Given this list of marker genes JADE1 (NCBI Gene Id 79960), SLC7A5P2, SGK3, SLC44A1, AP3B1, KLHL18, OBSL1, HSD17B12, VIM, FAXDC2, PNISR, DNAJC16, NAA38, STXBP2, POLL, PLPP1, ATP6V1G1, CCT7, TLE2, USP10, OIP5, PKMYT1, AKIRIN2, P4HA1, GNG12, NUDT5, RSRC2, ILF2, IQCK, EIF2AK3, ANP32A, CABLES1, DPPA4, H2AZ1, BAMBI, SPRY1, GANC, SNUPN, GBF1, TMEM160, SFT2D3, CETN3, AURKA, DCX, ZNF684, SNRPN, ING4, ZNF398, RPP25, CHD2, UBC, ELP6, RPRD1A, TTC31, GSK3A, APH1A, PHGDH, FAM131B, TSPAN6, RPS18, ZNF112, FAM124A, SP2, CAND1, SLC36A4, TMEM59, CLIC1, MOV10, FZD8, RYR3, PKIB, SNRNP70, NSD3, SELENOP, PSMD9, DDX20, HNRNPA2B1, MEF2A, VPS35, ERCC1, SPART, PEA15, LEFTY1, NOC3L, JUN, OGA, METTL8, OTUD7B, MZT2A, ID2, COA8, VCAN, AHSA1, ABHD2, GOLIM4, FOXO3, SF3B5, WWC3, BRK1 (NCBI Gene Id 55845), PPP2R3A, ZSCAN32, TCERG1, PLEKHG3, EIF4ENIF1, PHF8, BZW2, ARMC6, NT5C2, PEX1, PTN, C12orf60, DHDDS, THAP1, EXTL2, CTSV, ING1, PEX2, KRR1, RIPK1, PNMA1, CASP9, RNF25, PRPF31, DIDO1, TCF7L1, UXS1, CALB1, HMG20A, CKS2, AK4, TOP2A, TMEM109, DDX17, TAF4B, ARID5B, ERH, SEPTIN6, GTPBP3, CHST4, TRIP10, MSH2, TBL1XR1, ICMT, HNRNPH2, TRIML2, PPP1R16B, C1orf54, SPIRE2, PGAP3, FBXO31, ARIH1 (ariadne RBR E3 ubiquitin protein ligase 1), DDX5 (DEAD-box helicase 5), GGA1, POLR3D, STRN, AVL9, SLC7A5P1, C20orf96, MTFR2, B3GALT4, VWA5A, ENTPD1, TMEM108, TARBP2, GNPTAB, JUP, AP2A1, MLH1, FZD2, COMMD3, SCGB3A2, RAD54B, DDX39A, ERBB2, FGF2, TNPO1, FANCA, CDK1, CBX5, TDRP, ENPP2, PRPF38A, DDX18, SORBS1 (NCBI Gene Id 80057), BUB3, TLE3 (TLE family member 3, transcriptional corepressor), TIA1, UFM1, PREPL, CDK14, SERP1, WBP11, BMP2, HEXIM2, ZIC2, EPS15L1, PSENEN, FUS, RNF121, PIM2, NSMCE3, PRPF19, TMEM259, GART, CHCHD5 (NCBI Gene Id 84269), LSM5, ISOC2, FARSA (phenylalanyl-tRNA synthetase subunit alpha), ASCC2, TBCC, DDA1, SIN3B, CAVIN3, KLF5 (NCBI Gene Id 688), MRPL27, CYP1B1, NVL, GLUD1, RAI1, SART3, PALS2, POU5F1, RAD23A, RAB38, H2AX, SLIRP, SARAF, CA4, BAG5, SGK1, PWP1, DCAF13, PIPOX, CLN3, LEPROTL1, DYM, NEDD4L, TRPC4AP, PPP2R1A, MSL3, PPP2R1B, RPL21, AJUBA, ECPAS, H2BC5, SUPT4H1, GATAD1, ZSCAN10, DCAF11, GNAI1, BCKDHA, CFAP298, RARB, HMBOX1, IDH3A (isocitrate dehydrogenase (NAD(+)) 3 catalytic subunit alpha), FBXW11, MAP1LC3B, ZNF516, MTM1, TCEAL8, CCDC93, TFPT, RPS26, SEC24A, ZNF281, RAB25, LAMA4, RANBP10, COX6A1, INF2, GXYLT1, SLX1B, CLMP, TMEM208, EIPR1, TBK1, DDX49, TTF2, DNAJC2, CIBAR1, ZFP36L1, PSMB5, ADO, MORF4L1, ZNF521, USP3, VPS52, GPC6, VRK2, KLF7, ANKRD1, PNP, GLA, IGDCC4 (immunoglobulin superfamily DCC subclass member 4), PARP8, RBBP4 (RB binding protein 4, chromatin remodeling factor), IGF2BP3, COL4A6, PAPSS2, TRIP4, PRPF39, MOB3B, TXNRD1, MAPK14, OXA1L, SON, CEBPZ, NODAL, PITX2, EPHA1, FEZ1 (NCBI Gene Id 9638), HSPA5, UBE2T, CDC123, SEC22C, GYPC, DVL2, GRK3, PPP1R2, RAB5B, S100A11, RSPRY1, RRS1, TOMM40L, GLIPR2, RPS27A, ARID1B, POLR1A, RESF1, AP1S2, GOLGA4, DCTN5, MCTS1, MKRN1, DNAJC9, DNAAF9, LRRC49, TPX2, COG7, FEM1A, UBE2S, SPARC, CDYL, BAG6, RBM4, FOXO1, FANCF, TMEM245, RPLP1, AKIRIN1, HNRNPUL1, MAN2C1, OAZ2 (NCBI Gene Id 4947), ORC1, FAM72B (family with sequence similarity 72 member B), CA2, NKTR, AASDH, VOPP1, PSMD14, ALKBH1, IGFBP2, HCFC1R1, CFAP68, TSC22D1, RNF2, CPT1A, SEC22B, SDC4, NPAS2, PKIG, TFB2M, BCL9L, SENP2, BNIP1, ATP6V1A, SMAD3 (NCBI Gene Id 51521), QARS1, CEP20, CDC16, IRX2, GORASP2, ODF2L, PIP4P1, SNX1, ZEB2, COL4A5, SNRPE, B2M, RABL3, NUCKS1, MSC, PPIL3, TBL1X, SAV1, CDK6, CLIC4, LINGO1, CSTF3, CNOT8, WDR81, SUPT7L, SALL1, NDUFAF7, PIGL, ZC2HC1A, OTUB1, OSGEP, APLP2, PARG, CELF2, STK36, FDPS, HBP1, F11R, DSCC1, ATG4C, COTL1, H2AC18, WDTC1, CEP95, EIF4B, CACNA1A, PHF23, TMEM60, SC5D, STK11IP, ANKMY2, TAL1, SEMA4F, HAPSTR1, CARS2, CALD1, TMEM135, TIMP4, FAT1, GPC4, CCDC174, H2AJ, PHTF2, H2AC25, USP44, FXR1, WDR6, NAA30, IWS1, SHISA6, COPE, POU4F1, TIAL1, CITED2, NIP7, FXYD5, FZD7, NSUN3, MBOAT2, VIPAS39, SLC4A1AP, MKKS, DKK1, DHX38, MTMR1, NEBL, KHDRBS1, SEMA3C, NANOG, ANGPT1 (angiopoietin 1), FAM20C (NCBI Gene Id 56975), HNRNPA1, HECTD2, DMXL1 (NCBI Gene Id 1657), TTF1, SMARCAD1, ASB1, UIMC1 (ubiquitin interaction motif containing 1), CNMD, RBP1, FOXJ2, RAB5A, RNF24, WDCP (WD repeat and coiled coil containing), SGMS1, PCLAF, PLEKHA3, ALCAM, COMMD7, CBX3, NUSAP1 (nucleolar and spindle associated protein 1), ARHGAP11A, TAF12, UTP14A, EGLN3, KCTD2, RASA1, PCNX3, TMEM170A, KIF15, SUMO1, TERF1, MYO3A, WDHD1, UBR5, XAB2, CCT6B, ICMT-DT, MUS81, FRAT2, TIAM1, ZNF174, PLIN2, RPL32, RPS3A, BCL9, UBP1, RIC8B, ZNF185, ETNK1, EEF1E1, UFD1, KLHL4, WBP1L, DPM1, HMGN4, PRDM14, RGS10, NIF3L1, RASGRF2, NEMF, MINDY2, DPAGT1, ZNF551, ACSL4, AXIN2, KDR (NCBI Gene Id 3791), AMOTL1, ZNF436-AS1, NCOR1, TMEM43, CCN2, SALL2, ATP11C, ALG9, VRK3, SLC30A7, WDR77, TCF20, LRIG3, LYPD1, ZNF300, KIAA1217, TBP, PRNP, POU2F1, RASL11B, SSBP2, HOXB5, LEFTY2, GOLGA2P10, ATAD2, PPP2R5C, NAXD, EIF4G2, GTF3C4, CSTF1 (cleavage stimulation factor subunit 1), GNG10 (NCBI Gene Id 2790), EIF3D, ABRACL, KIF9, MRPL37, CFAP36, PERP, ADD3, GJA1, ANXA1, DPCD, VLDLR, GNA13 (G protein subunit alpha 13), ZFP42, DDIAS, TLCD1, TCAF1, RANGAP1, PSEN2, SERPINH1, HESX1, ORC6, EXOSC5, FBLN1, SERPINA1, CALR, ACTR1B, DHRS3, PBDC1, NCAPD2, DPYSL2, HLTF (NCBI Gene Id 6596), MOBP, HSPBAP1, NFAT5, TMEM205, CS, ILF3, SMDT1, CDC7, LMCD1, REST (NCBI Gene Id 5978), NDUFA13, CAV1, FBXL14, RAB17, LRAT, INPP4A, AP1G1, WDR36, IGFBP3, KCTD15, KIAA1143, PMEL, SMIM3, SFRP1, BCAT1, EHD4, PTPN1, MED25, RIF1, UBAP2, DRAM2, EIF3F, SNRPA, APOA2, TBC1D10B, SET, CSNK1E, CDH1, TRIM24, PDPN, RBM7, NDUFB3, MDH1, UBALD2, MPDZ, OSR1, LHPP, KCNN2, THBS2, CFL1, DARS2 (aspartyl-tRNA synthetase 2, mitochondrial), GSTT2 (NCBI Gene Id 91334), SLC49A4, KHSRP, URM1 (ubiquitin related modifier 1), ATF4, PPP2R3C, ZNRF2, DNAJB14, DCUN1D5, ABHD11, ZNF770, PDHB, FGFR1, KAT6A, MAPK8, ABCF2, MED23, DPYSL3 (NCBI Gene Id 54406), H4C3, ZNF202, FEM1C, ACTMAP, CACHD1, SUFU, HHEX, SKA2, ACADM, UBALD1, CNTNAP3, SCNN1A, GPR108, CIAO2A, GPN1, JOSD1, ARF3, SLC40A1, TMSB10, CEPT1, RNF31, DLGAP5, CYLD, THAP8, COL12A1, NFE2L3, SPRED1, CDK16, C1orf21, GRHL2, ITGB1, RETREG3, ZIC3, SUGP2, GRIPAP1, SFI1, SLC7A11, SAT2, LARGE1, PPFIBP1, JPT1, NFS1, KLHL5, MICB, MED12, BCLAF1, GRPEL2, MRE11, PRR11, CAAP1, PSMB1 (NCBI Gene Id 5689), FHIT, FANCL, GAS2L1, KANK1, SCAF1, IL1RAPL1, TALDO1, ANKRD49, DESI2, COL7A1, CER1, ATP5PB, SULF1, USP16, CRIPTO, IFT52, TNRC6A, LRFN3 (leucine rich repeat and fibronectin type III domain containing 3), MAP3K12, EXOC4, SLC7A5, ELL2, UBQLN4, SSBP3, ATG13, SF3B1, BLCAP, CNN2, NMT1, ASAH1, MMP2, RAB3GAP2, MAT2B, EPM2AIP1, ARF4, KNTC1, GALK2, EIF2A, PIH1D1, IER5L, DNAJC8, PRSS8, SCG5, RBM22, HSPA4, EOMES, APEX2, HAS2, LARP7, NOP16, NOLC1, KDM3A, AQP2, BSCL2, CCN1, CDS2, VRTN (NCBI Gene Id 55237), LSM3, PSMA1, IGFLR1, HELLS, ANO8, TYW3, TRIM16, VCPKMT, FOXN3, SECISBP2, UBE2W, EMC9, BUB1B, WEE1 (NCBI Gene Id 7465), LIN37, SS18L2, HEY2, DCAKD, CRYZ, ADAR, AK3, SOX2, RBPMS, ZNF331, ACAT2, IFI16, GATA6, PBX1, TRAF7, PSME3IP1, MPV17L2, ZIK1, SMG5, SKIL, EEF2, E2F3, RBM14, ARMCX1, CDK17, DUSP6, DTNA, CNBP, ACO2, ENSA, MYEF2, ST3GAL2, WDR20, GSTCD, GDF3, CDH2, TCEANC2, GTPBP1, ID1, OBI1, RFX1, MAPDA (NCBI Gene Id 161823), SASH1, GDE1, RUNX1T1, GSPT2, FKBP1B, PRCP, CNN3, KDM2A, GTF2E1, LCMT2, RAP1A, MMP9, ISCU, NME7, KPNA3, SRSF4, SERINC3, ZNF473, PDCL, CACNA2D1, RPS13, DNM2, SPAG9, LRP3, TMEM87A, ALKBH7, EHBP1, SALL3 (spalt like transcription factor 3), ANP32B, CYB5B, KATNBL1, TNC, LRRN1, R3HDM1, NBR1, CYP2R1, CALM2, B4GALT6, EXPH5, SLC1A1, DHCR7, SMIM7 (NCBI Gene Id 79086), ZNF217, DCLRE1C, PSMB4, AMIGO2, ZCCHC3, CDC42EP4, NAP1L2, TUBG1, BMP7, SCAF4, MCC, PCNA, PODXL, PIK3R2, SHLD2, NOL6, PTPN2, OLFML3, SFRP2, POLR3G, ZNF664, MARVELD2, STAT3, DTX2, INO80C, LRP2, PTCD3, ROMO1, IFT27, ASXL1, PCBP1, TMT1A, UBE2D3, PRORP, ACTR1A, WDR62, MICA, NAALAD2, WARS1, MLLT10, TXNDC5, EXD2, MAP3K11, RBFOX2, DUSP12, KIF26A, CISD1, GLG1, DDX23, ABCB7, TRIM22, TSC22D2, JARID2, TCF7L2, ATP5IF1, CAPZA2, ROR1, CXADR, RBM39, ZFAND6, MRAP2, RAB15, HIGD2A, TMEM63A, EXOSC9, FGFR2 (fibroblast growth factor receptor 2), ZNF226, UQCR10, ZNF286A, FERMT1, OSBPL1A, GTF2H2, CDC14B, NMU, RPL17, TNFRSF12A, TMEM123 (NCBI Gene Id 114908), NUP54, VAPB, USP7, MARCHF7, ARHGAP1, ZIC1, DDX41, YAP1, TMED10, MORF4L2, KDELR3, CDC45, CCDC12, SLC39A9, DPH6 (diphthamine biosynthesis 6), PALB2, SLAIN2, KRT18, APOB, STC1, LARS1, EMC7, ACOT8, FZD10, ZCRB1, PSMC2, ZNF701, APOM, NDUFS2, CYP2S1, YJU2, TIMM23B, KATNB1, CLDN6, SCNM1, UNC5D, INTS12, RRN3, PICALM, NADSYN1, here is a description of the gene set: from publication Ben-Porath I, Thomson MW, Carey VJ, Ge R, Bell GW, Regev A, Weinberg RA (PMID 18443585) Set 'Nanog targets': genes upregulated and identified by ChIP on chip as Nanog transcription factor targets in human embryonic stem cells. species: Homo sapiens Human Gene Set: BENPORATH_NANOG_TARGETS Cancer cells possess traits reminiscent of those ascribed to normal stem cells. It is unclear, however, whether these phenotypic similarities reflect the activity of common molecular pathways. Here, we analyze the enrichment patterns of gene sets associated with embryonic stem (ES) cell identity in the expression profiles of various human tumor types. We find that histologically poorly differentiated tumors show preferential overexpression of genes normally enriched in ES cells, combined with preferential repression of Polycomb-regulated genes. Moreover, activation targets of Nanog, Oct4, Sox2 and c-Myc are more frequently overexpressed in poorly differentiated tumors than in well-differentiated tumors. In breast cancers, this ES-like signature is associated with high-grade estrogen receptor (ER)-negative tumors, often of the basal-like subtype, and with poor clinical outcome. The ES signature is also present in poorly differentiated glioblastomas and bladder carcinomas. We identify a subset of ES cell-associated transcription regulators that are highly expressed in poorly differentiated tumors. Our results reveal a previously unknown link between genes associated with ES cell identity and the histopathological traits of tumors and support the possibility that these genes contribute to stem cell-like phenotypes shown by many tumors.